Given this list of marker genes Pdpk1, Lhx8, Skp1, Vsnl1, Ddx3x, Olfm3, Ctdspl2, Syt1, Rpf1, Eif4ebp2, Slc16a6, Snx7, Lgi2, Top1, Dld, Tox (thymocyte selection-associated high mobility group box), Ptbp2, Scml2, Mon1b, Rasa1, Atp5f1c, Mettl21c, Kbtbd6, Tmem131, Arih2, Ccz1 (NCBI Gene Id 231874), Baz1a, Trim59, Akr1c6, 1810010H24Rik, Ercc6, Zfp644, Cxxc4, Ptgfrn, Zfp619, Xk, Fam169a, Ppp3cc, Wfdc12, Adipor1, Gng10, Fkrp, Mfsd14b, Lamp2, Ddx3y, Angptl1, Fstl5, Tbc1d9, here is a description of the gene set: Genes predicted to be targets of miRBase v22 microRNA mmu_miR_382_5p in miRDB v6.0 with MirTarget v4 prediction scores > 80 (high confidence targets). Mouse Gene Set: MIR_382_5P from publication Chen Y, Wang X (PMID 31504780) species: Mus musculus